The following is a description of a gene set: Human Gene Set: GOBP_NEGATIVE_REGULATION_OF_BLOOD_VESSEL_ENDOTHELIAL_CELL_PROLIFERATION_INVOLVED_IN_SPROUTING_ANGIOGENESIS Any process that stops, prevents or reduces the frequency, rate or extent of blood vessel endothelial cell proliferation involved in sprouting angiogenesis. species: Homo sapiens, and this is the list of marker genes: IL12A, PDCD10, MIR193A, MIR222, DLL4, IL12B, MIR503, MIR149, MIR26A1, MMRN2, MIR424, THBS1, MIR24-1, MIR2355, MIR15A, MIR410, MIR494, MIR15B, MIR361, MIR29C, MIR342, NGFR, MIR483, MIR497, MIR16-1, MIR495